Given this list of marker genes Pias4, Pias1, Rasd2, Capn3, Hdac4, Rela, Hmg20b, Park7, Sae1, Fscb, Uba2, Ctnnb1, Gnl3, Ahrr, Sumo2, Rwdd3, Egr1, Mul1, Cdkn2a, Arnt, Pias3, Hmg20a, Traf7, Tollip, Gnl3l, here is a description of the gene set: Mouse Gene Set: GOBP_REGULATION_OF_PROTEIN_SUMOYLATION Any process that modulates the frequency, rate or extent of the addition of SUMO groups to a protein. species: Mus musculus